Given this list of marker genes ZFP91, NDUFS2, KCTD2, NUDT4, ANAPC16, COA6, ZNF23, SMG5, MYLK2, ACIN1, SNX21, CHKA (NCBI Gene Id 1119), CRIPTO, CBY2, KLHL42, WNT9B, SCT, KIF2C, SRP9, ZNF124, MYBPC3, PUF60, SOCS6 (suppressor of cytokine signaling 6), MGAT2, DSCAML1, PYCR2, SLC17A6, GARS1, NECAP1, RGS5, ADGRD1, IL21, TIMM29, SEMA3F, CELSR3, SHROOM3, KLC2, LRRC2, C6, MMP17, EIF1B, PLAAT1, CFTR, DCT, NEO1, INPP5K, STIMATE, GABRA3, PDHA1, CDPF1, C4orf19, GPS1, ERAS, WIPI1, GK2, WWOX, KRTCAP3, FZD3 (NCBI Gene Id 7976), PLEKHG5, CYP11A1, POLH, ZFP1, NTHL1, RASA1, AMDHD1, ZNF322, SNAP25, MNS1, COX6C, FANCE (NCBI Gene Id 2178), ST6GALNAC2, SMTN, ATG13, FKBP8, SNTG2, IFFO1, HAO1, SHC1, NHSL1, MYF5, SMIM8, SDHB, PDGFRB, MYL1 (myosin light chain 1), MTTP, MIEN1 (migration and invasion enhancer 1), TRADD, LSM3, EMP3, IL17D, TMCO5A, HR, CHST14, TXNIP, ADPRS, ART3, SLC1A2, PLCG1, MAN1B1, HIBCH, NCOA6, HHEX, CARTPT, RPP25, GNE, PCDHB14, FAM81A, WDR45B, AGGF1, CORO1C, DTNB, C9orf78, C1orf43, SYNPO2, KCND3, ACSM1, HASPIN, F11, SLC34A2, SLC66A2, ZNRD2, VWA1, TEX9, KLHL7, ZNF385A, KCTD1, CHST2, TBC1D17, PSME3 (proteasome activator subunit 3), TMEM30B, INA, GLIS1, SARAF, C19orf12, AGTR2, CAPRIN2, TP53RK (TP53 regulating kinase), MED22, OCA2, HBG2, PARVA, HHAT, RABGGTB, SLC35F6, XCL1, TNFRSF14, AKR1B15, NSG2, BCL11A, RPL3, BBS2, SSTR2, ASCL3, MRPS7, PADI3, PRKN, MRPL33, COPB2, FBXL14, HDAC9, PTPRR, GCLM, PROX1 (NCBI Gene Id 5629), S1PR3, PRKD1, BCAM, PDS5A, NSD1, CSF3R, COL4A6, LIMD1, ACOT1, SLC12A4, MSH5, SLC7A6, PSMC3, SYT9, CA6, BHLHE40, PPOX, TMA16, UBE2O, EDAR, RGS10 (regulator of G protein signaling 10), ITGA9, PSMB5, FAM117A, NATD1, JAK2, PDE6C, KCNK1, KIF23, MAP2K5, MEMO1, EFEMP1, MRPL20, IFNGR2, OR10A4, BET1L, SRP19, here is a description of the gene set: from publication Amit I, Garber M, Chevrier N, Leite AP, Donner Y, Eisenhaure T, Guttman M, Grenier JK, Li W, Zuk O, Schubert LA, Birditt B, Shay T, Goren A, Zhang X, Smith Z, Deering R, McDonald RC, Cabili M, Bernstein BE, Rinn JL, Meissner A, Root DE, Hacohen N, Regev A (PMID 19729616) studied in species Homo sapiens mouse primary BMDCs were stimulated with tlr ligands and gene expression changes were profiled on Affymetrix arrays Human Gene Set: GSE17721_LPS_VS_PAM3CSK4_2H_BMDC_DN Genes down-regulated in comparison of dendritic cells (DC) stimulated with LPS (TLR4 agonist) at 2 h versus DC cells stimulated with Pam3Csk4 (TLR1/2 agonist) at 2 h.